Given this list of marker genes ALCAM, LPAR1, SLC12A2, ZMYM6, TULP4, NR3C1, ZNF644, AKTIP, SLC25A36, CCDC88A, SNAPIN, COL3A1, RASA1, KIF16B, SMARCA2, TOP2B, IDI1 (isopentenyl-diphosphate delta isomerase 1), DDIT3, RAB9A, SHOX2, GADD45A, SNAI2, ICE1 (interactor of little elongation complex ELL subunit 1), AHR, ZFP62, RBM39, ATF2, ATF1, ZSCAN26, LIMS1, GAS1, LMO7, ACVR2A, NFIX, TBK1, PAXBP1, PNRC2 (proline rich nuclear receptor coactivator 2), CDH11, IRF1, EPHB3, AMOT, ATP6AP2, ARHGAP5, RNF13, SMS, GBP4, PKD2, PBRM1, KIF5B, MARCKS, ARFGEF1, here is a description of the gene set: Strongly down-regulated at 2-96 h during differentiation of 3T3-L1 cells (fibroblast) into adipocytes. During cellular differentiation and development, it is recognized that many complex molecular mechanisms as well as precise patterns of differentially expressed genes occur in directing precursor cells toward a given lineage. Using microarray-based technology, we examined gene expression across the course of 3T3-L1 adipocyte differentiation. Total cellular RNA was isolated at times 0, 2, 8, 16, 24, 48, and 96 h following treatment with either standard hormonal inducers of differentiation; insulin, dexamethasone, isobutylmethylxanthine (IDX), or IDX plus trichostatin A (TsA), a histone deacetylase inhibitor and potent adipogenic inhibitor. cRNA was synthesized from cellular RNA and hybridized to high density Affymetrix MG_U74Av2 microarray gene chips containing 12,488 cDNA/Expressed Sequence Tags (ESTs) probe sets. From the IDX-only treated cells, all probe sets that were either unchanged or differentially expressed less than 2-fold throughout differentiation with respect to time 0 preadipocytes were excluded from further analyses. This selection resulted in a net of 1686 transcripts, 859 were increased in expression, and 827 were decreased in expression at least 2-fold across differentiation. To focus in on genes that were more specific to differentiation, the same analysis was performed on IDX plus TsA-treated non-differentiating cells and all probe sets from the IDX-only group that exhibited similar expression profiles in the non-differentiating TsA-treated group were excluded leaving a total of 1016 transcripts that were regulated only under differentiating conditions. Six hundred and thirty-six of these transcripts were elevated at least 2-fold and 380 exhibited a decrease in expression relative to time 0 preadipocytes. This group of genes was further analyzed using hierarchical clustering and self-organizing maps and resulted in the identification of numerous genes not previously known to be regulated during adipocyte differentiation. Many of these genes may well represent novel adipogenic mediators and markers of adipogenesis. from publication Burton GR, Nagarajan R, Peterson CA, McGehee RE Jr (PMID 15033539) species: Mus musculus Human Gene Set: BURTON_ADIPOGENESIS_11